The following is a description of a gene set: species: Homo sapiens part of: SLC transporter disorders The SLC27 gene family code for fatty acid transport proteins (FATPs). Long chain fatty acids (LCFAs) are critical for many physiological and cellular processes as a primary energy source. Of the six FATPs characterised, three have been shown to mediate the influx of LCFAs into cells; FATP1, 4 and 6. SLC27A4 (FATP4) is the major intestinal LCFA transporter but is also expressed at lower levels in brain, kidney, liver and heart. SLC27A4 is also expressed in skin, where it has been shown to play a major role in epidermal development, being highly expressed in neonatal keratinocytes. Defects in SLC27A4 can cause ichthyosis prematurity syndrome (IPS; MIM:604194), a keratinisation disorder which is characterised by thickened epidermis and respiratory complications. Patients suffer from a lifelong non-scaly ichthyosis (Anderson & Stahl 2013). Reactome Pathway: Defective SLC27A4 causes ichthyosis prematurity syndrome (IPS), and this is the list of marker genes: SLC27A4